The following is a description of a gene set: Abnormally prominent umbilicus (belly button). Prominent umbilicus Human Gene Set: HP_PROMINENT_UMBILICUS species: Homo sapiens, and this is the list of marker genes: AGPAT2 (1-acylglycerol-3-phosphate O-acyltransferase 2), ZMPSTE24, FGD1, BSCL2, KAT6A, CAVIN1, LMNA